Given this list of marker genes HCN2, SCN2B, SCN1B, ANK2, SCN4B, SCN10A, CACNA1C, CACNA1G, HCN4, ATP1A2, SLC8A1, RANGRF, CLCN2, SLMAP, PTPN3, SCN5A, KCNH2, ANK3, MIR208A, SCN1A, TRPM4, SCN11A, KCNJ2, CACNB2, SCN3B, CACNA1D, YWHAH, CACNA2D1, CAV3, SCN3A, GJA5, here is a description of the gene set: The process in which membrane potential changes in the depolarizing direction from the negative resting potential towards the positive membrane potential that will be the peak of the action potential. Human Gene Set: GOBP_MEMBRANE_DEPOLARIZATION_DURING_ACTION_POTENTIAL studied in species Homo sapiens